The following is a description of a gene set: Binding to a class V myosin; myosin V is a dimeric molecule involved in intracellular transport. species: Homo sapiens Human Gene Set: GOMF_MYOSIN_V_BINDING, and this is the list of marker genes: RAB39B, RAB3B, RAB3D, RAB27B, RAB10, RAB6B, RAB6A, RAB11B (RAB11B, member RAS oncogene family), RAB3C, RAB8A, RAB3A, RAB25, RAB11A, NPC1L1, RAB14, GRIA1, RAB27A